Given this list of marker genes TLK1, TCF12, SLC35B3, GVINP1, MYNN, RAB8B, GTDC1, CACNB4, IFNAR2, MAP3K5, ZNF217, PDE4B, P4HA1, CRADD, KLF6, ICA1, PTK2B, COBLL1, ST6GAL1, HBS1L, FAM91A1, OPRM1, LRIG1, ANKRD11, ELK3, RBBP6, SPP1 (NCBI Gene Id 6696), FAS, LATS2, SAG, CC2D2A, USF3, AGPAT5, CD226, FAM107B, RP9, ENPP6, S1PR1, KDM3A, MAP4K4, ZBTB20, SLAMF1, TNRC6B, PTGER2, TSPAN13, MAP3K1, PPP1R3F, BTBD10, STAT5B, TLR6, DENND5A, SLC30A7, SMAD3, GPD2 (glycerol-3-phosphate dehydrogenase 2), ARL4A, SLC23A2, ZPBP2 (NCBI Gene Id 124626), PPP3CC, ZC3H12D, CCDC198, ATP2B1, HEXIM1 (NCBI Gene Id 10614), CIPC, TTC39B, EXOC2, RB1, BZW2, RAPGEF6 (NCBI Gene Id 51735), USP6NL, AHR, ANKH, RAPGEF2, SAMHD1, OR2V1, P2RY10BP, ARHGAP5, IBTK (inhibitor of Bruton tyrosine kinase), FAM169BP, PARK7, SRPK1, PARM1 (prostate androgen-regulated mucin-like protein 1), PSMD4, RAP1A, FAM76B, EXOC6B, STK17B, CD200, PSRC1, CD96 (NCBI Gene Id 337949), ZBTB2, LRCH1, NR2E3, SCN8A, NCK2, BCL6, VOPP1, FASLG, RAB3IP, FEM1C, MLLT3 (NCBI Gene Id 4300), F2RL1, AKR1D1, MAP3K8, CHD2, HMG20A, PTGER4 (prostaglandin E receptor 4), NSMCE2, RMI2, ACTR3, TBC1D15, BICDL1, TP53INP1, ATXN7, MS4A6A, CYTH1, RPL37, WDR37, CNOT6L, TRA2B, NR5A2 (nuclear receptor subfamily 5 group A member 2), ANXA1, ARID5B, TG, SAMSN1, PSMA1 (NCBI Gene Id 5682), SHTN1, TPP2, RCBTB2, SPEF2, ANKRD44, SCML4, AGO2, PTPN22, WDR35, NSMCE1, ARHGAP25 (Rho GTPase activating protein 25), SMAP2, IKZF2, RHOH (ras homolog family member H), TMEM64, RFX3, DUSP6 (dual specificity phosphatase 6), FAM3C, RGS13, INPP4B, IFT80, LCP1, GRK6, ITPR2, KBTBD11, RAD51C (NCBI Gene Id 5889, RAD51 paralog C), PARP8, DENND6A, SSH2, TBC1D4, GGTA1, BEND6, SOCS2, UBASH3B, CDKN1B, PIP4K2A, NEK7, VPS37B, MDFIC, NDUFV2, AQR, ASXL1 (NCBI Gene Id 23393), MACF1, RRAS2, CELF2, ANKRD28, RNF125, AKAP13, PELI1, HK3, DYNLT5, CNGA1, C21orf91, TOP2B, CCR7, HEATR5A, BANP, FYN, STAT4, CD200R1, TRAT1, ABLIM1, CLCA1, GATA3, L3MBTL3, ATP8A2, HIF1A, CTLA4, RBL1, PRRG4, MAN1A2, APBB1IP, PRKAR2B, ABTB2, ADAMTS6, CX3CR1, ARL6, CDK17, ESYT2, AIM2, MRPL39, MGAT5, TRIM59, PRKCH, RGS1, ADAM19, HJV, FRS2, MDM2, TMEM67, PTGER3, FRMD4B, C4orf46, MS4A7, ST6GALNAC5, ETNK1, GRB14, ENPP1, TET3, SPMIP7, LNX2, FERMT1, CHD7, SNCA, GIMAP4, CREM, FOXP1, ANKRD55, GATB, INTS9, COL11A1 (NCBI Gene Id 317718), PEBP4, LARS1, KNL1, PDE7A, WDR45, NSMAF, SDR16C5, ZNF595, TNFSF11, NR4A2, AMOT, SESN1, SPG7, PVT1, PRKCQ, ICOS, LSM5, ARHGEF3, C15orf48, GBP6, TMEM71, BCL2, DTX4, NUDCD3, GIMAP1, CADM3, USP3, E2F6, PIK3CG, CNOT2, VPS54, MBNL1, P2RY10, SBSPON, JAK1, TEC, ZBTB1, ETS1, STK10, CLEC2D, ECI2, DAD1, UTP3, IL7R (NCBI Gene Id 3575), TBC1D30, CYTIP, DAPL1, OSBPL8, ITGA6, TBC1D5 (TBC1 domain family member 5), NOX3, CDH10, KLF2, PAG1, NT5E, ADSS2, TRIB1, SNX9, ADD3, CD44, PHTF2, TMSB4X, SGMS1, NIPBL, NFKBIZ, FYB1, ELMO1, PRDM1, MAMDC2, GPHN, KAT6B (NCBI Gene Id 23522), TESPA1, EPB41, SH3KBP1, TMCO1 (NCBI Gene Id 54499), RGS10, PTPRK, UBE2H, GRIA3, EPS15L1, REEP3, CAMK4 (NCBI Gene Id 814), NINJ2, NDC80, MALT1, TOX, AXL, B3GNT2, MT-ND4L, DOCK10, SPTBN1, SELL, LDLRAD4, UBAC2, OTULINL, LEPROTL1, URM1, CR1L, EVI5, UST, VWF, ASXL2, ENOX1, PTBP3, PPP2R5C, EXT1, CWC27, IDH1, TRIB2, NCOA3, ATP6V1G3, RASA3, XPO4, RCSD1, CDC42SE2, CDK19, GPR18, ZBTB25, GABRG1, XXYLT1, PRAG1, FLI1, EOLA1, IL2RA, TTC5, IFIT3, TRIM27, ZNRF1, GNG2, BCL11B, TENT5C, SH2D1A, NUP153, TMEM222, MRS2, CPOX, TUBE1, UTRN, DIPK1A (divergent protein kinase domain 1A), MRTFA, IL10RB, NSD3, RABGAP1L, ARHGAP15, KLF3, CMAHP, AGPS, WIPF1, CADPS, FERRY3, ZFP91, TNFAIP3, NUS1, ITM2B, CEP97, ARHGEF10, MUC20, TMEM252, CORIN, FLT3, GLCCI1, IFT57, VCPKMT, ATP1B3, PYM1, VGLL4, GIMAP6, CHURC1, PTPRC, SYNE2, ST8SIA4, XCL1, FBLN5, KDSR, TBCCD1, HERPUD2, AMPH, GDI2, GPR65, CD69, ETV3, IFNG, RDM1, TLR8, ZC3HAV1, CAST, LRRC8C, HERC3, TGFBR2, SLC35B4, SUMF1, PARP11, SGCE, RBL2, SATB1, POLI (NCBI Gene Id 11201), IMPA1, LRRC66, IL6ST (interleukin 6 cytokine family signal transducer), NRP1, ZFAND6, RRM2, SP100, LEF1, MAN1A1, NT5C3A, GLDN, NR4A3, THADA, TAF8, TASP1, OBI1, PLCG1, ZNF608, SLAMF6 (SLAM family member 6), TRAV18, C3orf38, CPE, TRAV5, GPRIN3, JARID2, JMJD1C, GPR183, CITED2, BTLA, ELF1, ST8SIA1, ULK4, PGAP1, AGGF1, SELP, ABT1, IRF4, LTA4H, EEF1E1, MIR4435-2HG, SNX14, PGBD1, HECTD1, LLPH, ZDHHC20, CD28, ZNF121, TRAF3IP3, C2CD5, RAB19, SIK3 (SIK family kinase 3), IRF2, NRIP1, ZAP70, PIAS2, CBLB, STK24, HIVEP2, IFNGR1, THEMIS, ZFP36L2, CD53, here is a description of the gene set: from publication Zheng Y, Josefowicz SZ, Kas A, Chu TT, Gavin MA, Rudensky AY (PMID 17237761) Transcription factor Foxp3 (forkhead box P3), restricted in its expression to a specialized regulatory CD4+ T-cell subset (T(R)) with a dedicated suppressor function, controls T(R) lineage development. In humans and mice, Foxp3 deficiency results in a paucity of T(R) cells and a fatal breach in immunological tolerance, causing highly aggressive multi-organ autoimmune pathology. Here, through genome-wide analysis combining chromatin immunoprecipitation with mouse genome tiling array profiling, we identify Foxp3 binding regions for approximately genes and for an intergenically encoded microRNA. We find that a large number of Foxp3-bound genes are up- or downregulated in Foxp3+ T cells, suggesting that Foxp3 acts as both a transcriptional activator and repressor. Foxp3-mediated regulation unique to the thymus affects, among others, genes encoding nuclear factors that control gene expression and chromatin remodelling. In contrast, Foxp3 target genes shared by the thymic and peripheral T(R) cells encode primarily plasma membrane proteins, as well as cell signalling proteins. Together, our studies suggest that distinct transcriptional sub-programmes implemented by Foxp3 establish T(R) lineage during differentiation and its proliferative and functional competence in the periphery. Human Gene Set: ZHENG_BOUND_BY_FOXP3 species: Mus musculus Genes whose promoters are bound by FOXP3 based an a ChIP-chip analysis.